Given this list of marker genes VTA1, CHMP7, VPS4A, VPS4B, CHMP1A, CHMP5 (charged multivesicular body protein 5), CHMP2A, IST1, CHMP2B, CHMP1B, here is a description of the gene set: Human Gene Set: GOBP_ESCRT_COMPLEX_DISASSEMBLY The disaggregation of an ESCRT complex into its constituent components. species: Homo sapiens